Given this list of marker genes SMAD7, THBS3, MSX1, CLP1, KRT2, INSR, KRT1, ZNF212, PRRX2, PKP1, CTAG1B, SLC12A2, PDE4A, DCBLD2, TRO (NCBI Gene Id 7216), NR5A1, NCBP2, INPP5K, IRF2, RABIF, UGCG, F2, SNRPD1, FMR1, LGALS7, EIF3I, DRD4, PTPRN, KCNA5, DARS1, ADAM8, IFNAR2, UBE2K (ubiquitin conjugating enzyme E2 K), CTBS, TM9SF1, MICA, PREP, HAAO, TARS1 (threonyl-tRNA synthetase 1), LIPE, ITIH1, EIF2B2 (eukaryotic translation initiation factor 2B subunit beta), RRH, GYPA, IGBP1, CDH4, BCL2L1, USF1, ACTR1B, BTN2A2, WNT10B, HCCS, RTCA, PDK2, OTUD4, PTPRG, HPS1, SNURF, PFKFB3, here is a description of the gene set: Human Gene Set: MODULE_322 studied in species Homo sapiens Genes in the cancer module 322.